Given this list of marker genes Fbxo5 (NCBI Gene Id 97658), Cdkn2a, Usp44, Dtx3l (deltex 3-like, E3 ubiquitin ligase), Psen2, Rpl5, Abl1, Rpl11, Park7, Psen1, Rps7, Smad7, Mad2l2, Bag2, Mad2l1, Rpl23, Bag5, Limk1, here is a description of the gene set: Any process that stops, prevents, or reduces the frequency, rate or extent of ubiquitin transferase activity. Mouse Gene Set: GOBP_NEGATIVE_REGULATION_OF_UBIQUITIN_PROTEIN_TRANSFERASE_ACTIVITY studied in species Mus musculus